Given this list of marker genes Gpr3, Oprm1, Chga, Ucn, Crhr2 (NCBI Gene Id 12922), Gip, Gipr, Ghrh, Crhr1, Crh, Pebp1, Taar1, Ptger3, Ece1, Ptger4 (NCBI Gene Id 19219), Adcyap1, Insl3, Rxfp2, Adcyap1r1, Sctr, Adora2b, Sct, here is a description of the gene set: Mouse Gene Set: GOBP_POSITIVE_REGULATION_OF_CAMP_MEDIATED_SIGNALING Any process which activates, maintains or increases the frequency, rate or extent of cAMP-mediated signaling. species: Mus musculus